The following is a description of a gene set: Mouse Gene Set: GOBP_INTRACELLULAR_AMINO_ACID_HOMEOSTASIS studied in species Mus musculus A homeostatic process involved in the maintenance of a steady state level of amino acids within a cell., and this is the list of marker genes: Grm2, Slc7a11, Slc38a3, Atg7, Fmr1, Slc1a1, Kctd7, Gls, Slc66a1, Acacb, Tpp2